Given this list of marker genes Il1b (NCBI Gene Id 16176), Ppp1r15a, Zfp36, Hspa1a, Fosb, Btg2, Neat1, Ier2, Hspa1b, Fos (NCBI Gene Id 14281), Junb, Jun, Dusp1, Pmaip1, Tsc22d3, Klf2, here is a description of the gene set: species: Mus musculus Mouse Gene Set: CUI_CDC2_FASL_RESPONSE_DN Genes negatively differentially expressed in cell type: cDC2 (conventional dendritic cell type 2) upon treatment with cytokine: FasL in mouse lymph nodes in vivo. Cytokines mediate cell-cell communication in the immune system and represent important therapeutic targets. A myriad of studies have highlighted their central role in immune function, yet we lack a global view of the cellular responses of each immune cell type to each cytokine. To address this gap, the authors created the Immune Dictionary, a compendium of single-cell transcriptomic profiles of more than 17 immune cell types in response to each of 86 cytokines (>1,400 cytokine-cell type combinations) in mouse lymph nodes in vivo. A cytokine-centric view of the dictionary revealed that most cytokines induce highly cell-type-specific responses. For example, the inflammatory cytokine interleukin-1β induces distinct gene programmes in almost every cell type. A cell-type-centric view of the dictionary identified more than 66 cytokine-driven cellular polarization states across immune cell types, including previously uncharacterized states such as an interleukin-18-induced polyfunctional natural killer cell state. from publication Cui A, Huang T, Li S, Ma A, Pérez JL, Sander C, Keskin DB, Wu CJ, Fraenkel E, Hacohen N (PMID 38057668)